The following is a description of a gene set: Genes negatively correlated with memory B cell response in peripheral blood mononuclear cell in adults (50-74) after exposure to trivalent inactivated vaccine (A/California/7/09 (H1N1,), A/Perth /16/2009 (H3N2), and B/Brisbane/60/2008)., time point 3D. Comment: Association of baseline, early and late gene expression changes with peak memory B cell ELISPOT response (Day 28 - Day 0) in older individuals BACKGROUND: Studies suggest that the recall-based humoral immune responses to influenza A/H1N1 originates from activated memory B cells. The aim of this study was to identify baseline, early and late blood transcriptional signatures (in peripheral blood mononuclear cells/PBMCs) associated with memory B cell response following influenza vaccination. METHODS: We used pre- and post-vaccination mRNA-Seq transcriptional profiling on samples from 159 subjects (50-74years old) following receipt of seasonal trivalent influenza vaccine containing the A/California/7/2009/H1N1-like virus, and penalized regression modeling to identify associations with influenza A/H1N1-specific memory B cell ELISPOT response after vaccination. RESULTS: Genesets and genes (p-value range 7.92E(-08) to 0.00018, q-value range 0.00019-0.039) demonstrating significant associations (of gene expression levels) with memory B cell response suggest the importance of metabolic (cholesterol and lipid metabolism-related), cell migration/adhesion, MAP kinase, NF-kB cell signaling (chemokine/cytokine signaling) and transcriptional regulation gene signatures in the development of memory B cell response after influenza vaccination. CONCLUSION: Through an unbiased transcriptome-wide profiling approach, our study identified signatures of memory B cell response following influenza vaccination, highlighting the underappreciated role of metabolic changes (among the other immune function-related events) in the regulation of influenza vaccine-induced immune memory. from publication Haralambieva IH, Ovsyannikova IG, Kennedy RB, Zimmermann MT, Grill DE, Oberg AL, Poland GA (PMID 27317456) Human Gene Set: HARALAMBIEVA_PBMC_TIV_AGE_50_74YO_CORRELATED_WITH_MEMORY_B_CELL_RESPONSE_3DY_NEGATIVE species: Homo sapiens, and this is the list of marker genes: KRT10-AS1, CHMP4A, RAD51C, CDK4, ACTL10, BLCAP, DHRS13, TTLL1, LRP11, MAP4, PMVK, EEF1E1-BLOC1S5, THAP3 (THAP domain containing 3), ZNF780B, ZNF233